The following is a description of a gene set: from publication Travaglini KJ, Nabhan AN, Penland L, Sinha R, Gillich A, Sit RV, Chang S, Conley SD, Mori Y, Seita J, Berry GJ, Shrager JB, Metzger RJ, Kuo CS, Neff N, Weissman IL, Quake SR, Krasnow MA (PMID 33208946) studied in species Homo sapiens Human Gene Set: TRAVAGLINI_LUNG_MUCOUS_CELL, and this is the list of marker genes: CRYM, PIGR (NCBI Gene Id 5284), TMC5, SOD2, HLA-DQA1, LTF, LCN2, MUC5B, RHOV, HILPDA (hypoxia inducible lipid droplet associated), CFB, CXCL3, SCGB3A1, RDH10, SERPINF1, CTSC, LYN, ATP12A, SCGB1A1, XBP1, BPIFA1, CTSB, CDC42EP5, GPX3, HLA-DQA2, CCL2, SLC4A4, IGFBP3, TMEM165, CBR3, MSMB, ANPEP, LINC00342, HIPK2, ANKRD36C (ankyrin repeat domain 36C), SAA1, S100A9, SRD5A3, BACE2, TGM2, TNIP3, PTGES (prostaglandin E synthase), FCGBP, LIF, AZGP1, SLC26A2, CP, ZG16B, MED24, SMIM31, LY6E, PI3, CX3CL1, RPS26, BPIFB1, PROM1, AKR1C2, ADM, DUSP23, BID, TNFSF10, PLK2, KYNU, LAG3, IFITM1, KLK12, CXCL1, KLK11, PTP4A3, NHERF2, RIMS1, WFDC2, PDZK1IP1 (PDZK1 interacting protein 1), C3, REEP3, TMEM45A, DUSP5, HS3ST1, TNFAIP2, AKR1C1 (NCBI Gene Id 9418), CPD, KLK10, UBD, CRISP3, TFPI2, SLPI, CCL20, DEFB4A, CXCL6, RASD1, CSTB, MUC4, TFF3, IDO1, MUCL1, SERPINA3, MMP7, IL6, CXCL10, INSR (NCBI Gene Id 3643), SAT1, STT3B (STT3 oligosaccharyltransferase complex catalytic subunit B), SLC26A4, RARRES1, ASS1, S100P, CYP2F1, CXCL8, ALDH1A3, SAA2, VMO1, C15orf48, ST3GAL1, TSPAN8, SLC5A5, CSF3, ERO1A, MDK, TIMP1, ADAM28, CLU, HSD17B2, IRAK3, KDR, SORD